The following is a description of a gene set: Neoplasm of the nervous system species: Homo sapiens Human Gene Set: HP_NEOPLASM_OF_THE_NERVOUS_SYSTEM A tumor (abnormal growth of tissue) of the nervous system., and this is the list of marker genes: MAFA (NCBI Gene Id 389692), MDH2, MN1, MSH6 (NCBI Gene Id 2956), PDE6D, GCDH, GRN, CHMP2B, RB1 (RB transcriptional corepressor 1), GPC3, PRDM16, RPL10, GABRD, LBX1, SPTBN1, DLST, RET, IFNG, BRCA2, ALK, CASZ1, ASXL1, KDM1A, SDHC, TSC2, POLE, MYO1H, NUTM1, SLC25A11, TIAM1, CCND1, TRAPPC14, VCP, DNMT3A, SIX6, PDGFB, KARS1, CHEK2, WRN, PRKCZ, ALX3, APC, COL14A1, GLI3, FLI1, SDHAF2, ZFTA, TMEM127, IDH2, TCTN3 (NCBI Gene Id 26123), MAN2C1, AAGAB, PTCH1, RERE, APC2, KIT, CPLANE1, PTCH2, MSH3, LMO1, SETBP1, GDNF, EP300, TOPORS, NSD1, PDPN, ARMC5, WDPCP, SPEN, SKI (SKI proto-oncogene), ERBB2, RUNX1, PALB2, KEAP1, TREM2, KLLN, ATRX, VANGL1, KRIT1, MNX1, GNAS, FH, EPHB2, KCNAB2, LIN28B, GCGR (NCBI Gene Id 2642), STAT6, BRAF (B-Raf proto-oncogene, serine/threonine kinase), EIF3F, SUFU, KIF1B, PTPN11, LUZP1, FGFR1, MMP23B, SMARCE1, SDHB, NAB2, NRAS, SOX2, BDNF, IDH1, VPS16, RAF1, MAPT, GPR161, TGFBR2, PIK3CA, ATM, CREBBP (CREB binding protein), ADAMTS3, HSPG2, HRAS, DICER1, TMEM231, BAP1, ALX1, TMEM106B, KIF7, EWSR1, NF1, CDKN1A, FAT4, SDHA, PMS2, MBD4, ASCL1, L2HGDH, PMS1, ELP1, FAM149B1, UBE4B, NBN, CDKN1B, CCBE1, RNF43, PRKAR1A, SEMA4A, MAPRE2 (NCBI Gene Id 51683), SPRED1, MAX, EDN3, MYCN, CCM2, KIAA0753, SMO (NCBI Gene Id 6608), SDHD, GPC4, SEC23B, TSC1, PTEN, BMPR1A, CDKN2B, VHL, MEN1, YY1, LRP1, RPS20, KCNJ11, LZTR1, MDM2, MUTYH, POLD1, TMEM216, OFD1, BRD4, TP53, USF3, PDCD10, PSEN1, PDE11A, NTHL1, LMNA, OCRL, CTNNB1, NOTCH3, HACE1, PHOX2B, TERT, SMARCB1, COQ6, TUBB, PDGFRB, MSH2, EPAS1, WT1, CDKN2C, NF2, EPCAM, CDKN2A, AKT1, MLH1, TRAF7, ZSWIM6, KRAS